The following is a description of a gene set: Mouse Gene Set: GOBP_PURINE_NUCLEOSIDE_MONOPHOSPHATE_METABOLIC_PROCESS studied in species Mus musculus The chemical reactions and pathways involving purine nucleoside monophosphate, a compound consisting of a purine base linked to a ribose or deoxyribose sugar esterified with phosphate on the sugar., and this is the list of marker genes: Nt5c2, Gmps, Adk, Atic, Nt5c, Dguok, Pals2, Ampd3, Entpd1, Urah, Pals1, Ampd2, Ada, Pfas, Impdh1, Slc29a1, Dck, Paics, Ak4, Gda, Urad, Ak1 (NCBI Gene Id 59018), Gmpr, Prps2, Aprt, Nt5c1b, Ampd1, Ak2, Xdh, Dnph1, Gmpr2, Adsl, Ppat, Impdh2, Nudt2, Nt5c1a, Adss1, Hprt1, Nt5e, Ak3, Adss2, Pnp, Uox, Gart, Guk1